The following is a description of a gene set: species: Homo sapiens The process of restoring DNA after damage. Genomes are subject to damage by chemical and physical agents in the environment (e.g. UV and ionizing radiations, chemical mutagens, fungal and bacterial toxins, etc.) and by free radicals or alkylating agents endogenously generated in metabolism. DNA is also damaged because of errors during its replication. A variety of different DNA repair pathways have been reported that include direct reversal, base excision repair, nucleotide excision repair, photoreactivation, bypass, double-strand break repair pathway, and mismatch repair pathway. Human Gene Set: GOBP_DNA_REPAIR, and this is the list of marker genes: DDX11, XRCC6, FANCF, FAN1, UNG, UBE2V2, CEBPG, ERCC6, CDK7, HINFP, MCM8, MIR221, EMSY, PMS2P5, RNF111, CHEK1, RNASEH2B (ribonuclease H2 subunit B), UBE2NL, GTF2H2, DNA2, HROB, CHRNA4, BCCIP, TAF6, EYA1, PALB2, DCLRE1B, CHAF1A, SMUG1, BABAM2, ABL1 (NCBI Gene Id 25), ACTL6A, PPP4R3C, NFRKB, RAD18, ASCC1, UBE2D3, ALKBH3, CDC45, PMS2P6, CDKN2D, POLQ, UBR5, ASTE1, HERC2, PNKP, TADA3, POLE, ZBTB1, SMARCAL1, TP73, CENPS (NCBI Gene Id 378708), PRPF19, FZR1, MORF4L2, KAT7, CSNK2A3, RAD1, RNASEH2A, GTF2H2C, TDP1, RFC5, DHX9, MAJIN, RBX1, PARP10, ALKBH1, SPIRE2, FBXW7, ASCC3, ERCC1, UPF1, SLX1B, SFPQ, SHLD2, NSMCE3, FANCI (NCBI Gene Id 751608), EPC2, UBE2V1, RHNO1, SETMAR, NONO, HELB, SETD2, SMC3, DCLRE1A, ERCC8, ASF1A, EYA2, MCM6, HDAC10, POLD4, RIOX1, KMT5B, FAM111A, PRMT6, ATM, MCM2, USP51, FAAP20, NTHL1, RADX (RPA1 related single stranded DNA binding protein, X-linked, NCBI Gene Id 79994), SMARCA2 (NCBI Gene Id 95083), DDB1, JMY, SLF2, PMS1, WDR48, TOP2B, ACTL6B, FAM168A, ACTR5, SSRP1, XPA, SF3B5, MPG, EME2, XNDC1N, INO80B, ZMPSTE24, INTS3, FIRRM (FIGNL1 interacting regulator of recombination and mitosis), IFFO1, EME1, NABP2, FAAP100, POLE2, TP53, TADA2B, RAD17, UBE2B, TAF5L, ERCC6L2, AUNIP, RPA2 (NCBI Gene Id 6118), CUL4A, BRD8, FANCM, RAD51B, NSMCE2, BOD1L1, REXO4, TFPT, KASH5, ATRX, FBXO6, PIAS4, DCLRE1C, PDS5B, XPC, POLR2I, RAD9B, ALKBH2, MCM5, SPIDR, TTC5 (NCBI Gene Id 91875), TEX15, EYA3, KDM4D, LIG1, ZRANB3, PMS2, TAF4, SUPT20H, SHLD1, HUWE1, CIB1, CHD4, GTF2H3, TADA1, LIG4, POLK, DEK, EPC1, ARID1A, USP43, SUPT16H, ERCC4, MUS81, MRE11, ARID1B, POLD1, HMCES, SUPT3H, PPP4R3B, CSNK2A2, SHPRH, C11orf54, CENPX, TOP3B, APTX, KIN, SUV39H1, ESCO2, SUMO1, TAF10, PPP4R3A (protein phosphatase 4 regulatory subunit 3A), CDK9, USP22, H2AC25, PELI1, HMGN1, SMC5, INO80, H2AX, RECQL5, TDP2, GTF2H4, UBQLN4, ZNF668, RAD9A, MC1R, RNF169, ATR, PRKCG, ZNF365, CRY2, MARCHF6-DT, PDS5A, TAF12, ERCC2, PARPBP (NCBI Gene Id 55010), NEURL4, PTTG1, RAD51D, UBE2A, GINS2, EXO5, TERB2, UBE2U, WDR33, SKP2, RNF168, LIG3, RFC2, MRGBP, RNF138, SENP3, CDC7, POLH (NCBI Gene Id 5429), PRDM9 (PR/SET domain 9), USP1, SMARCD1, NBN, OTUB1 (NCBI Gene Id 55611), POLN, BRD7, SMARCA5, TERF2IP, PMS2P1, CDK2, SMARCC2, MEIOC, NUCKS1, MAGEF1, TRIP12, KAT2B, ATP23, PARP2, FANCC, VPS72, CDCA5, DNTT, BCL7A, SMC1A, RFC4, KDM2A, HLTF, MACROH2A1, PARP1, TNKS1BP1, RNF113A, NPM1, TTF2 (NCBI Gene Id 8458), MSH6, MARF1, SMARCC1, PPP4C, USP44, ATXN7, PRIMPOL, FANCA, SEM1, USP45, ERCC5, CBX8, USP3, UFL1, RAD23A, TOP3A, RPA1, OGG1, TRIP13, RUVBL1, TENT4A, TEX12, ERCC3, CDC14B, MMS19, FANCD2, ACTR8, C1QBP, MSH5, PIF1, PARP4, ANKLE1 (ankyrin repeat and LEM domain containing 1), GGN, MCM3, CLSPN, REC8, GTF2H5, DTX3L, MDC1, MRNIP, FAAP24, CUL4B (cullin 4B), TAF5, SMARCE1, EP400, BTG2, BRME1, FUS, BLM, ZMYND8, TAOK3, MCM4, AXIN2, NEIL2 (NCBI Gene Id 252969), UVRAG, C14orf39, DOT1L, PARP9, GINS4, KMT5A, MBTD1, RFC3, POLDIP2, XRCC2, DYRK1B, EXO1, PAGR1, PSMD14 (NCBI Gene Id 10213), HSF2BP, PBRM1, CINP, RFWD3, EXOSC10, OTUD4, TWIST1, ZCWPW1, SIRT7, NOP53, SLF1, CYREN, FMN2, TRIM28, SMG1 (NCBI Gene Id 23049), HELQ, FIGNL1, USP10, XAB2, BABAM1, MNAT1, OOEP, ZFYVE26, POLD2, MCRS1, STUB1, RTEL1, CHEK2, AGER, TAF9, CCDC117, RRM2B, PWWP3A, POLA1, HMGB1, APEX2, UCHL5, PLK1 (polo like kinase 1), TAOK1, ING3, RAD21, GEN1, RAD23B, SPATA22, XRCC1, MLH3, FANCB, KLHL15, VCP, RPA4, EGFR (NCBI Gene Id 1956), FANCL, MSH4, NSD2, YY1, AKTIP, SMCHD1, POLM (NCBI Gene Id 27434), CHAF1B, MORF4L1, RECQL, BRIP1, DPF1 (double PHD fingers 1), DPF3, MMS22L, ENY2, RMI1, NPAS2, DDX1, MAD2L2, RAD54L, EXD2, CDK1, SWI5, PARP3, UHRF1, NUDT16L1, UBE2T, CHD1L, RAD51C, MCM7, NEIL1, HDGFL2, TONSL, HMGA1, TERB1, ATXN7L3, CGAS, WRNIP1, KDM1A, RRM1, USP7, ABRAXAS1, ZBTB7A, USP9X, SMARCD3, SFR1, WAS, TRAIP, FH, RAD52, EYA4, TIGAR, SLX1A (SLX1 homolog A, structure-specific endonuclease subunit), TEX264, GADD45A, RAD51, POLI, AP5S1, INIP, CETN2, MEIOB, PRKDC, POT1, MLH1, TOPBP1, SHLD3, BACH1, CSNK2A1, NUDT1, SLC30A9, UIMC1, HPF1, MUTYH, RFC1, PARK7 (NCBI Gene Id 113880), ENDOV, UVSSA, KIF22, HUS1B, ACTR2 (NCBI Gene Id 10097), MSH3, DDB2, RBBP8, RNASEH2C, HSF1, TDG, CDC5L, HMGA2, RCHY1, INO80E, SMARCB1, RPS3, SMC6 (NCBI Gene Id 79677), TAF7, CEP164, TICRR, COMMD1, USP28, IER3, INO80D, PRMT1, SIRT6, CSNK1E, ADPRS, BCL7B, XRCC3, ETAA1, PMS2P3, SUPT7L (SPT7 like, STAGA complex subunit gamma), DMAP1, RECQL4, USP47, BARD1, TFIP11, FANCG, MBD4, SF3B3, TP53BP1, BCL7C, HTATSF1, RUVBL2, FBH1, NSMCE4A, NME3 (NCBI Gene Id 96012), BRCA2, RPA3, MGMT, TIMELESS, RNF126, XRCC4, SYCP1, INO80C, KAT5, TMEM161A, PSME4, BRCC3, HMGB2, GCNA (germ cell nuclear acidic peptidase), BRCA1, XRCC5, NSMCE1, GTF2H1, MEAF6, CREBBP, SPIRE1, TREX2, REV3L, KMT5C, TAF6L, WDHD1, CTBP1-DT, PCLAF, WRAP53, SETX (NCBI Gene Id 85506), POLB, PCNA, KHDC3L, MTA1, FANCE, POLL, TREX1 (NCBI Gene Id 82474), TRRAP, DMC1, RAD50, STK19 (NCBI Gene Id 8859), SIRT1, ARID2, VCPIP1, MEN1, FOXM1, RBBP4, TERF2, UBE2W, ACTB, ZGRF1, SPRTN, SGF29, SMARCD2, REV1, WRN, RAD51AP1, TAF2, PAXIP1, ATXN3, FEN1, NABP1, MCM9, DPF2, ZSWIM7, RAD54B, NIPBL, HUS1, ATRIP, RNF8, SPO11, EEPD1, SWSAP1, PPP4R2, UBE2N, FGF10, APEX1, RIF1, PARG, PAXX, SAMHD1, SMARCA4, FMR1, TNP1, ERCC6L, NEIL3, POLG, PPP5C, RMI2, APLF, RAD21L1, DTL, MGME1, MSH2, PML, ASCC2, POLD3, MPND, NHEJ1, YEATS4, SLX4, AP5Z1, POGZ, FTO, PHF10, GTF2H2C_2, MCMDC2, SMARCAD1, EID3, NYNRIN, ELOF1, SETD7, KAT2A